The following is a description of a gene set: Human Gene Set: HP_LARYNGEAL_STENOSIS species: Homo sapiens Laryngeal stenosis Stricture or narrowing of the larynx that may be associated with symptoms of respiratory difficulty depending on the degree of laryngeal narrowing., and this is the list of marker genes: FRAS1, FERMT1, ADAMTSL2, FREM2, DDRGK1, MYMK, MYMX, EXTL3, KIF22, SLC26A2, GRIP1, LAMA3, SMAD4, FLNB, LAMC2, LAMB3